The following is a description of a gene set: Mouse Gene Set: GOBP_MONOCARBOXYLIC_ACID_BIOSYNTHETIC_PROCESS studied in species Mus musculus The chemical reactions and pathways resulting in the formation of monocarboxylic acids, any organic acid containing one carboxyl (-COOH) group., and this is the list of marker genes: Ces1a, Gstm4, Acsm2, Pkm, Rdh9, Dhrs9, Abhd2, Elovl6, Fads1, Thnsl2, Ceacam2 (NCBI Gene Id 26367), Prox1, Prkag1, Abhd1, Cyp1a1, Mthfd2, Acly, Acsl1, Scd4, Gstp1, Acaca, Pla2g1b, Apoc2l, Cbr4, Pla2g3, Acox2, Alox8 (arachidonate 8-lipoxygenase), Elovl1, Ido1, Ces1e, Rgn, Gamt, Cd74, Aldh1a1, Wdtc1, Plp1, Acadvl, Fabp5, Acsf3, Anxa1, Alox12b, Mlycd, Acadl, Eif6, Asah2, Acss1, Slc27a2, Ltc4s (leukotriene C4 synthase), Nr1h3, Rdh16, Slc45a3, Gstp-ps, Hnf1a, Tmem135, Insig2, Pex2, Olah, Fgfr4, Ces1c, Erlin2, Abcd3, Srr, Brca1 (breast cancer 1, early onset, NCBI Gene Id 12189), Ubr4, Ptges3, Gip, Cyp8b1, Insig1, Oxsm, Cyp7a1, Myo5a, Degs1, Ces1f, Cyp27a1, Acsbg3, Elovl7, Cyp7b1, Pnpla8, Fa2h, Baat, Amacr, Avpr1a, Gstm1, Nr1h2, Sco1 (NCBI Gene Id 67104), Elovl5, Agxt, Pla2g10, Ptgis, Fasn, Apoa4, Acacb (NCBI Gene Id 97267), Alox5, Acss2, Scd1, Sphk1, Dcaf5, Fads6, Pecr, Tecrl, Hoga1, Sds, Acaa1a, Alox12, Gstm6, Tbxas1, Hacd1, Acsm5, Mapk9, Ehhadh, Acot8, Rdh1, Hnf4a, Erlin1, Hacd3, Star, Rdh10, Ceacam1, Pla2g2a, Gstp2, Gstm2, Htd2, Sirt2, Hsd17b12, Fgf15, Lipc, Ndufab1, Hsd17b10, Scp2 (NCBI Gene Id 99990), Ptgds, Acsl3, Ces1b, Elovl3, Cyp39a1, Aldh8a1, Slc27a5, Prmt3, Acsl4, Acsm3, Apoc3, Prkaa2, Edn2, Scd2, Gatm, Apoc1, Mgll, Acsm1, Avp, Acsbg1, Acaa1b, Stard4, Aloxe3, Gstp3, Errfi1 (ERBB receptor feedback inhibitor 1), Pklr, Mthfd1l, Park7, Abhd3, Edn1, Malrd1, Daglb, Abcd2, Akr1d1, Hacd2, Acox1, Ldhc, Ptges3-ps, Lipg (NCBI Gene Id 73116), Kmo, Fads2, Elovl2, Gstm7, Aldh1a2, Apoc2, Hsd17b8, Lpgat1, Apoa5, Decr2, Fads2b, Pnliprp1, Ces1d, Mecr, Cthrc1, Acsm4, Il1b, Kat2b, Pla2g4f, Prxl2b, Akr1c18, Elovl4, Ptgs1, Tecr, Rbp1, Rdh16f2, Prkab1, Rdh19, Srebf1 (NCBI Gene Id 276754), Mif, Mlxipl, Fads3, Trib3, Hsd17b4, Pla2g4a (phospholipase A2, group IVA (cytosolic, calcium-dependent)), Agt, Nr1d1, Abcd1, Pnliprp2, Ptges, Mid1ip1, Prkag3, Lias, Gstm3, Htt, Ldha, Pibf1, Shmt2, Prkab2, Hacd4, Sirt1, Acot7, Per2, Alox15, Ces1g, Mcat, Qki, Aldh1a3, Ptges2, Prkaa1, Acsbg2, Pdk4, Scd3, Pnlip, Prkag2, Ces1h, Hpgds, Klhl25, Lpl, Scap, Ptgs2, Ldhb